Given this list of marker genes Lig1, Prim1, Pold1, Dna2, Pold2, Pola1, Pola2, Rfc1, Rpa1, Rfc3, Pcna, Pold4, here is a description of the gene set: studied in species Mus musculus electronically inferred by orthology from the curated human pathway Reactome Pathway: Lagging Strand Synthesis This event has been computationally inferred from an event that has been demonstrated in another species.<p>The inference is based on the homology mapping from PANTHER. Briefly, reactions for which all involved PhysicalEntities (in input, output and catalyst) have a mapped orthologue/paralogue (for complexes at least 75% of components must have a mapping) are inferred to the other species. part of: DNA strand elongation